The following is a description of a gene set: Human Gene Set: GOBP_LENS_MORPHOGENESIS_IN_CAMERA_TYPE_EYE studied in species Homo sapiens The process in which the anatomical structures of the lens are generated and organized. The lens is a transparent structure in the eye through which light is focused onto the retina. An example of this process is found in Mus musculus., and this is the list of marker genes: TDRD7, ABI2, EPHA2 (NCBI Gene Id 1969), CRYAA, NECTIN1, BMP4, SIX3, MEIS1, CRYGB, SOX1, ATF4, BCAR3, HIPK1, PROX1, SKI, SOX11, PITX3, CTNNB1, SHROOM2, LCTL, CITED2, TBC1D20, HIPK2, NECTIN3